Given this list of marker genes SIN3B, VIM, FGL2, PNPLA6 (patatin like phospholipase domain containing 6), COTL1, KLF13, NLRP1 (NCBI Gene Id 82286), IER5, ANXA2, TNFSF13B, TYMP, LST1, TSPAN32, CFP, CEBPB, BCL2A1, HLA-B, C1orf162, NBPF10, MAFB, HLA-A, EFHD2, ADA2, CALHM6, IRF1, CD74, ITGAL, CFD, S100A9, ANXA1, UTRN, PLAUR, HLA-DRA, ARF6, SOCS3, KLF2, TKT, HLA-DPA1, FXYD5, CD300E, LILRA5, HLA-DPB1, SCIMP, PLAC8, HLA-DRB1, GRK2, SERPINA1, CSTA (cystatin A), FCN1, KLF4, AIP, MYO1F, LY6E, CLEC2B, CXCR4, IFI30, PLEKHO1, PRAM1, NAPSB, CTSS, LYZ, MT2A, S100A8, NAMPT, ARHGEF2, ITGAX, LSP1, GPBAR1, EMP3, JAML, TXNIP, TGFBI, LGALS1, SPI1, LRRFIP1, S100A11, WIPI2, MX2, IFI44L, DOK2, CRIP1, ISG15, HCK, MS4A6A, APOBR, SECTM1 (NCBI Gene Id 6398), ATF3, STXBP2, S100A10, LRRC25, CSK, CPPED1, PTGS2 (prostaglandin-endoperoxide synthase 2), NEAT1, PTP4A2, IFITM3 (NCBI Gene Id 10410), CLEC12A, CHCHD10 (coiled-coil-helix-coiled-coil-helix domain containing 10), DNAJA4, ADGRE5, HLA-DMA, CD48, AP1S2, TMEM176B, LILRB3, VCAN, WARS1, NFKBIA, TNFAIP2, CD52, PLCB2 (phospholipase C beta 2), C5AR1, TMEM131L, NFKBIZ, IFITM2, POU2F2, HCST, LILRB2, APOBEC3A, RETN, IQGAP1, TIMP1, S100A4, HSPA7, TNFRSF14, CLEC7A (C-type lectin domain containing 7A), S100A6, PANK2, CD44, RIPOR2, OSCAR, PLXNB2, CHD1 (chromodomain helicase DNA binding protein 1), HLA-DQB1, FGR, CARD16, PSMB9, TRIM25, TENT5A, here is a description of the gene set: from publication Fan X, Dong J, Zhong S, Wei Y, Wu Q, Yan L, Yong J, Sun L, Wang X, Zhao Y, Wang W, Yan J, Wang X, Qiao J, Tang F (PMID 29867213) Human Gene Set: FAN_EMBRYONIC_CTX_BRAIN_MYELOID studied in species Homo sapiens